Given this list of marker genes PTPMT1, PLD6, PLD1, PLD4, CDS2 (CDP-diacylglycerol synthase 2), PLD3, PGS1, PLD2, here is a description of the gene set: species: Homo sapiens Phosphatidylglycerol (PG) is synthesised at the inner mitochondrial (IM) membrane, phosphatidic acid (PA) and cytidine triphosphate (CTP) are converted into cytidine diphosphate-diacylglycerol (CDP-DAG), which in turn is converted with glycerol-3-phosphate (G3P) into phosphatidylglycerophosphate (PGP) and cytidine monophosphate (CMP). Finally, PGP is dephosphorylated to PG. In addition, PG can be synthesised at the endoplamic reticulum (ER) membrane when phospholipase D transphosphatidylates phosphatidylcholine (PC) with glycerol to displace choline (Cho) and form PG (Piazza & Marmer 2007, Stuhne-Sekalec et al. 1986, Lykidis et al. 1997, Cao & Hatch 1994). part of: Glycerophospholipid biosynthesis Reactome Pathway: Synthesis of PG